Given this list of marker genes Fyn (Fyn proto-oncogene), Cltb, Tspan13, Elob, Scimp, Tgfbi, Rbx1, Ide (insulin degrading enzyme), Tspo, Ldha, Ms4a6d, Fkbp2, Cdk2ap2, Ppp1r14a, Ifitm2, Calr, Ngfr (NCBI Gene Id 18053), Bcl3, Mdh2, Cd53, Gadd45g, Pfn1, Cd244a, Smdt1, Atp5mc1, Hip1 (huntingtin interacting protein 1), Actr3, Flot1, Rap1a, Pirb, Socs3, Tmem256, Cyrib, Gpr146 (NCBI Gene Id 80290), Gatm, Akt2, Gimap1, Pkm, Srgn, Ndufb7, Cyp7b1, Spi1, Coro1a, Fgr, Gsr, Ptpn1, Lyn, Crip1, Rnh1, Ccnd3, Hnrnpf, Ddr1, Casp6, Fabp5, Psma7, Olfm1, Slfn2, Ly6a, Spint1, Pitpna, Cd300a, Ifitm1, Gpr35, Gprc5c, Napsa, here is a description of the gene set: Cytokines mediate cell-cell communication in the immune system and represent important therapeutic targets. A myriad of studies have highlighted their central role in immune function, yet we lack a global view of the cellular responses of each immune cell type to each cytokine. To address this gap, the authors created the Immune Dictionary, a compendium of single-cell transcriptomic profiles of more than 17 immune cell types in response to each of 86 cytokines (>1,400 cytokine-cell type combinations) in mouse lymph nodes in vivo. A cytokine-centric view of the dictionary revealed that most cytokines induce highly cell-type-specific responses. For example, the inflammatory cytokine interleukin-1β induces distinct gene programmes in almost every cell type. A cell-type-centric view of the dictionary identified more than 66 cytokine-driven cellular polarization states across immune cell types, including previously uncharacterized states such as an interleukin-18-induced polyfunctional natural killer cell state. Mouse Gene Set: CUI_CDC2_CARDIOTROPHIN_1_RESPONSE_UP Genes positively differentially expressed in cell type: cDC2 (conventional dendritic cell type 2) upon treatment with cytokine: CT-1 in mouse lymph nodes in vivo. from publication Cui A, Huang T, Li S, Ma A, Pérez JL, Sander C, Keskin DB, Wu CJ, Fraenkel E, Hacohen N (PMID 38057668) studied in species Mus musculus